Given this list of marker genes Il4ra, Nppc, Il13, Syk, Sphk2, Ms4a2, Pla2g3, Stxbp1, Il4, Crhr1, Gata2, Stxbp2, Nppa, Adora2b, Vamp8, Adora3, Snx4, Fcer1a, Pld2, Fcer1g (Fc receptor, IgE, high affinity I, gamma polypeptide), Gab2, Gata1, Fgr, here is a description of the gene set: Mouse Gene Set: GOBP_POSITIVE_REGULATION_OF_MAST_CELL_DEGRANULATION species: Mus musculus Any process that activates or increases the frequency, rate or extent of mast cell degranulation.